Given this list of marker genes MIR214, KLF4, MEF2A, MYOCD, BORCS8-MEF2B, CCND2, SRF, MIR143, MIR145, MEF2C, ELK1, MIR133A2, MEF2B, CAMK2D, MIR199A1, MIR133A1, NKX2-5, MEF2D, here is a description of the gene set: Human Gene Set: WP_SRF_AND_MIRS_IN_SMOOTH_MUSCLE_DIFFERENTIATION_AND_PROLIFERATION species: Homo sapiens SRF and miRs in smooth muscle differentiation and proliferation